Given this list of marker genes IKZF1, PGM1, PARVA, KIFC3, CD27 (NCBI Gene Id 939), REM1, ABHD5, KCND3, CCNF, SRRM1, HDGF, CNBP, TTC3, ABCC3, MDFIC, PPP1R11, MAP3K5, LRRC8B, DCHS1, PRRC1, C1QL1, IL15RA, CHD9, TFAP4, THOC2, PUM2, EAPP, PTPN22, ZBTB5, AR, UCP3, FMR1, AZIN1, SULF1 (NCBI Gene Id 23213), TRIM16, PLPBP (pyridoxal phosphate binding protein), WBP4, CAPZA1, SH3BP5, LETMD1, CLINT1, UBE2V2, LEPROTL1, DLEC1, EEIG1, RAP1B, UCK2, ATP1B3, STAG2, USP12, ARL4A, NFX1, ARR3, GPATCH8, CRYBA4, ADCY6, DDX11, SLA, IFNGR1, IL17RA, TAB2, NXF1, TGOLN2, ZMYM2, PIP5K1A, LAMB3, FOSL2, MAPKAPK5, COL4A5, S1PR1, EPB41L3, VPS35L (NCBI Gene Id 57020), NDP, GTF3C1, CPNE1, SREBF1, KRT9, PBX2, PCSK5, GGPS1, CD40, DOCK4, CTBS, CLDND1, DHX29, ABL1 (NCBI Gene Id 25), TP53BP2, CAMSAP2, GNRH2, ATOSB, SUSD5, OSMR, TNNC2, TNP1, CTDSPL, KDELR1, SRSF9, TXN, DENND3, SPINK4, CTNNB1, PSG11, CHUK, PDLIM5, SH3BGRL, TOMM34 (translocase of outer mitochondrial membrane 34), WSB2 (WD repeat and SOCS box containing 2), RSBN1, LIN37, ACP1, UBXN4, HARS2 (NCBI Gene Id 23438), LRIG2, HSP90AB1, KHDRBS3, TRIM33, PLP2, SUMO3 (NCBI Gene Id 6612), MOAP1, TUBB4B, PTPRCAP, NECAB3, DDR1, IL10RB, PXN, ACSL4, MICAL3, PDHX, MAT2A, TRIM37, ODC1, ADD3, OXSR1 (NCBI Gene Id 9943), GSAP, CSF2RB, TRIB1, OTUD4, PES1, PHIP, TRAF5, DHX15, PTAFR, LDLR, FAM98A, PEX3, ECM2, SLC30A1, CDH16, DDC, SERPINE2, PHF8, THBS2 (NCBI Gene Id 7058), MBOAT7, IDS, PF4, PYGM, IL9R, GTF2H1, ATP5PB, ADAM8, NHLH1, CPQ, INPP5B, PDXDC1, HNRNPA2B1, STXBP3, URB2, BCL2L1, HNRNPH2, AMHR2, PIGA, KRT2, TDG, NCBP2, LUZP1, IQSEC2, FUT6, NFATC2IP, SPINT2, RABGAP1L, MUC6, SCN9A, STT3A, DNAJB9, MACF1, SNAP23, ANKRD46, CD46, VEZF1, ITGB4, HTR6, CDK2AP2, UBE2D2, UTRN, CKAP4, ZFR, KRT10, NIPSNAP2, APBB3, here is a description of the gene set: Genes down-regulated in comparison of macrophages versus macrophages exposed to L.donovani. studied in species Homo sapiens Human Gene Set: GSE360_CTRL_VS_L_DONOVANI_MAC_DN from publication Chaussabel D, Semnani RT, McDowell MA, Sacks D, Sher A, Nutman TB (PMID 12663451) Monocyte-derived dendritic cells (DC) and macrophages (MΦ) generated in vitro from the same individual blood donors were exposed to five different pathogens, and gene expression profiles were assessed by microarray analysis. Responses to Mycobacterium tuberculosis and to phylogenetically distinct protozoan (Leishmania major, L. donovani, Toxoplasma gondii) and helminth (Brugia malayi) parasites were examined, each of which produces chronic infections in humans yet vary considerably in the nature of the immune responses they trigger.